The following is a description of a gene set: from publication Howe DG, Blake JA, Bradford YM, Bult CJ, Calvi BR, Engel SR, Kadin JA, Kaufman TC, Kishore R, Laulederkind SJF, Lewis SE, Moxon SAT, Richardson JE, Smith C (PMID 30224793) studied in species Mus musculus Mouse genes annotated to HALLMARK_KRAS_SIGNALING_DN based on orthology mappings provided by the Alliance Genome Consortium Mouse Gene Set: HALLMARK_KRAS_SIGNALING_DN, and this is the list of marker genes: Ryr2, Egf, P2rx6, Snn, Klk7, Smpx, Sgk1, Mast3, Ntf3, Prop1, Prodh, Thnsl2, Synpo, Clps, Lypd3, Slc5a5, Klhdc8a, Calcb, Cyp11b2, Krt1, Tent5c, Hc, Tff2, Tgm1, Actc1, Sphk2, Itih3, Tfcp2l1 (transcription factor CP2-like 1), Oxt, Bard1, Fshb (NCBI Gene Id 14308), Ribc2, Krt15, Col2a1, Cd40lg, Mthfr, Igfbp2, Krt5, Cyp39a1, Ccr8, Hsd11b2, Edar, Ptprj, Krt13, Lfng, Camk1d, Grid2, Nr4a2, Shox2, Tas2r108, Msh5, Nphs1, Chrng, Entpd7, Abcb11, Zfp112, Slc25a23, Sptbn2, Ybx2, Efhd1, Slc30a3, Tgfb2, Kmt2d, Magix, Pdk2, Tcl1, Vps50, Sidt1 (SID1 transmembrane family, member 1), Mx2, Il12b, Gamt, Htr1d, Edn1, Coq8a, Alox12b (arachidonate 12-lipoxygenase, 12R type), Gp1ba, Myh7, Hnf1a, Gpr19, Zc2hc1c, Fgf16, Krt4, Insl5, Ptgfr, Kcnd1 (NCBI Gene Id 68749), Idua, Myo15a, Cldn8, Scn10a, Atp6v1b1, Gprc5c, Ypel1, Pcdhb1, Adra2c, Macroh2a2, Tshb, Mefv, Edn2, Tfap2b, Tex15, Stag3, Bmpr1b, Cpeb3, Ifng, Brdt, Itgb1bp2, Asb7 (ankyrin repeat and SOCS box-containing 7), Gtf3c5, Nr6a1, P2ry4, Ryr1 (NCBI Gene Id 20190), Sprr3, Gdnf, Fggy, Pnmt, Ambn, Cpb1, Slc16a7, Ckm (creatine kinase, muscle), Ifi44l, Dtnb, Nos1, Nrip2, Epha5, Kcnn1, Slc6a14, Chst2, Abcg4, Sncb, Capn9, Celsr2, Htr1b, Calm4, Ccdc106, Pax3 (paired box 3), Lgals7, Sstr4, Serpina10, Il5, Sox10, Irs4, Tg, Dcc, Tnni3, Pdcd1, Kcnmb1, Fgf22, Gp2, Ccna1, Selenop, Cntfr, Cd207, Rgs11, Slc6a3 (solute carrier family 6 (neurotransmitter transporter, dopamine), member 3), Btg2, Gpr3, Tcf7l1, Plag1, Tlx1, Tenm2, Skil, Cldn16, Zbtb16, Cdh16, Cd80, Kcne2, Mfsd6, Dlk2, Fgfr3, Cdkal1, Slc29a3, Thrb, Arhgdig, Pkp1 (plakophilin 1), Ngb, Arpp21, Slc38a3, Pde6b, Pax4 (paired box 4), Cacng1, Wnt16, Slc12a3, Cacna1f, Scgb1a1, Kcnq2, Cpa2, Myot, Serpinb2, Atp4a, Prkn, Klk8, Rsad2, Clstn3, Copz2